The following is a description of a gene set: Human Gene Set: GOBP_NEGATIVE_REGULATION_OF_CELL_POPULATION_PROLIFERATION studied in species Homo sapiens Any process that stops, prevents or reduces the rate or extent of cell proliferation., and this is the list of marker genes: RC3H1, ABI1, P3H3, MIR200B, MAP2K1, PTPN1, PEX2, DNAJA3, MIR205, MIR15A, CNN1, GLMN, MIR26A1, WDR6, MIR1298, RNF139, MYOCD, SLIT3, MIR24-1, TP53, VTCN1, ACVR1C, MIR17HG, CCL3L3, PIM2, NUPR1 (NCBI Gene Id 26471, nuclear protein 1, transcriptional regulator), IFT52, SMAD6, CTLA4, LGALS9B, TNF, ZBTB7B (zinc finger and BTB domain containing 7B), JARID2, WNK2, MIR29C, PLPP1, PTPRU, PTGIR, HSPG2, MARCHF7, IL4I1, CERS2, BTG2, TESC, IGFBP7, TOB2, PPARD, NFIB, MYOD1, CD80, MED31, SFN, NF1 (neurofibromin 1), HMGA1, MIR4632, MIR221, EIF2AK2, CXCL8, MAGI2, DPT, IFNK, PLA2G5, FKTN, FGFRL1, WDR13, BCHE, NDRG4 (NCBI Gene Id 65009), CD300A, MIR495 (NCBI Gene Id 574453), STK4, NTRK1, CD33, TYROBP (transmembrane immune signaling adaptor TYROBP), MIR361, ECRG4 (NCBI Gene Id 84417), OVOL1, PHF14, MED25, IL12B, TMEM127, CCL8, ABCC8, TGIF1, ALDH1A2, MIR494, SULT2B1, AR, C1QL4, MIR20B, CER1, PTEN, CELF1, GATA3, NR2E3, PTPN2, CSK, ATP5F1A, APP, PAX6, VAX1, HGS, OVOL2, DLL1, PDCD10, TOB1, NDRG1 (NCBI Gene Id 7998), MIR22, KAT2B, MIR362, RBP4, SPARC, CLMN, KDM2B, WT1, PLAAT4, TAFA5, APLN, CHD5, MIR223, BTK, KLF9, ZBTB7C (NCBI Gene Id 649379), CLDN19, AXIN2 (NCBI Gene Id 8313), TENT5B, IL24, ATP8A2, PTPN14, RNF10, EMD, TMIGD3, SSTR4, P3H1, MIR181A2, AZGP1, SULF1, FZD5, ETS1, TREM2, ACKR3, MFN2, PKD2 (polycystin 2, transient receptor potential cation channel), SFRP5, SMARCA2, CGREF1, FLCN, SH2B3 (SH2B adaptor protein 3), IL12A, GABBR1, SYNJ2BP, HAVCR2, MN1, IFNLR1, MIR675, FABP7, GATA6, EAF2, SPEG, PHF7, ROBO1, ANG, MARVELD3, DRD2, UMOD, NMI, CSF1R, F2R (coagulation factor II thrombin receptor), RAPGEF2 (Rap guanine nucleotide exchange factor 2), GML (glycosylphosphatidylinositol anchored molecule like), BMP2, TNFRSF8, CSNK2B, HSPA1A, RNF41, MYC, NIBAN2, MIR133A1, ATG101, TNMD, TNFAIP3, ADAMTS1, MSX2, LGALS9, LILRB1, ZBTB17, TSG101, SLC16A2, MIR182, CCL23, NR2F2, IGFBP6, CDKN1A, CDKN2B, PAK1, MIR181C, FABP3, E2F1, SNAI2, IDO1, FLT1, MIR483, DELEC1, AGBL4, SSTR2, ZBTB49 (zinc finger and BTB domain containing 49), ADAMTS8, BRCA2, PAWR, FGFBP1, PTPRJ, MIR137, INTU, HRAS, DACH1, CTBP2, RBM38, PML, ETV3, IER3IP1, PRDX4, TMIGD1, RBM10, PHB2, GSDME, PDCD4, MIR199A1, IL20RB, OSM (NCBI Gene Id 5008), LAPTM5, DAB2, SOX11, ILK, FOXJ1, KLF13, NUP62, LYN, RARA, PTPN11, MIR204, FRZB, SLC6A4, BTN2A2, MYOG, LST1, IFT74, SH3BP4, MIR34A, PINX1, CRP, BCL6, ATG13, ADORA1, IAPP, ENG, TRIM24, HSF1, HNF4A, MIR16-1, GPC3, CYP27B1, DUX4, CDKN1B, GDF11 (NCBI Gene Id 10546), COL4A3, TGFB1I1, DAB2IP, WDR77, ATP5IF1, EEF1E1, PTPRK, MEN1 (menin 1), TNS2, PODN, BMP4, WNT11, CDKN2D, MIR320A, FXYD2, WNT10B, ACVRL1, MIR185, ATRAID, NUPR2, LILRB2, NPR1 (NCBI Gene Id 4881), FBXO2, MIR143, SMAD1, NCK2, IFNG, MIR329-1, MIR711, PLA2G2A, NGFR, CTCF, FABP6, ITCH, ULK1, PDX1, IFT80, MIR335, BAX, TINF2, HLA-DRB1, MTBP, FGF10, MSTN, ZBTB16, MIR34B, TSC1, TAF6, LILRB4, INPP5D, CD200, FEZF2, MIR2355, IFT57, ADGRG1, BMP7, TES (testin LIM domain protein), HPGDS (hematopoietic prostaglandin D synthase), IL2, RGS5, JAK2, VDR, GNRH1, IFNL1 (NCBI Gene Id 282618), H2AC8, CCN6 (cellular communication network factor 6), DLEC1, H2AC6, FOXP3, ATOH8, ERBB2, BAP1, TFAP2B, MIR92A1, SAV1, ING4, APOH, MIR486-1, FAP, SSTR3, PHB1, ADORA3, XCL1, KCNK2, MORC3, CNMD, TFDP1, CD86, FBLN1, ACE2, CCL2, NACC2, TNFRSF14, FGF2, KRT4, MED1, FOXO4, FBXW7, HLA-E, TMEM115, THAP12, KANK2, SRF, FGFR2, PTGES, MIR499A, RARRES1, AGTPBP1, ASPH, CDK10, MIR93, CLDN3, H2AC4, VSIG4, DHRS2, CDK6, S100A11, PARP10, NOG, KIFAP3, MIR140, SFRP2, LRRC32, PTPN6, BMPR1B, MIR503, A4GNT, LDOC1, GNA12, SMAD3, MIR20A, TRIM32, DLC1, CD109, SPIN4, MIR342, MIR1-1 (microRNA 1-1), RAP1GAP, SIX5, PKN1, CEACAM1, SCIN, STK3, SERPINE2, KMT2A, MTSS1, CBFA2T3, EFEMP2, PTHLH, DUSP10, P3H2, SMARCB1, HPN, INSM1, LIMS2, COL18A1, NF2, DSC1, INHBA, SLC4A2, MIR665, NUDT6, PLA2G2D, TP53INP1, LIF, BCL11B, RASSF5 (Ras association domain family member 5), MIR133B (microRNA 133b), TPM1, KLF4, MDM4, TSC22D1, PDPN, DDX20, TP73, DICER1, MNDA, MIR410, DLG3, SMAD4, SPINT2, MEF2C, CCN3, MIR9-1, DLG5, ARG2, TNFRSF9, MIR424 (NCBI Gene Id 494336), BECN1, IFT172, MIR34C (NCBI Gene Id 407042), GDF5, MIR152, MIR125B1, CDH5, CDKN2C, KRIT1, MIR497, PLA2G2F, E2F3, IGFBP3, LMNA, FTH1, SLURP1, GHRL, CDKN2A, DIS3L2, HRG, MAD1L1, KCTD11, SKI, ITGA1, TFAP4, APOD, MIR132, SPINT1, NKX2-8, ZNF503, SIRPG, BMPR2, COPS8 (COP9 signalosome subunit 8), GDF2, B4GALT1, PDCD1LG2, IL6, EIF2AK1, VGLL4 (NCBI Gene Id 9686), VASH1, PRNP, ENPP7, ARID2, KDF1, EPPK1, MIR195, TGFB2, ADORA2A, SPRY1, PBRM1, SCGB1A1, PRKAR1A, CEBPB, MIR125A, IL1B, NPM1, CTNNBIP1, RAF1, TP53I11, NME1, EPHB1, MIR492, ING5, CGRRF1, MMRN2, MIR15B, GPER1, CDC73, PMP22, STAT1, GPLD1, TSPAN32, MAGED1, LZTS2, WARS1, SRPX, HSPA1B, SFTPD, WWC2, PTH1R, ATM, SMAD7, CNOT7, SOD2, LTA, NOX4, LBX1, PTCH1, IGF1, MYO16, MIR10A, MIR29B1, ZEB1, NELL1 (neural EGFL like 1), B4GALT7, TNFRSF21, MIR30B, BTG1, TSC2, GAS8, FCGR2B, DHCR24, STRN, BMP5, FNIP1 (folliculin interacting protein 1), NKX3-1, CEND1, CTBP1, MSX1, SSTR5, RXFP2, IRF6, EREG (NCBI Gene Id 2069), FEZF1, ALOX5, PRKG1, GPNMB, TGFB3, GSTP1, SOX10, JUN, ATF5, DLL4 (NCBI Gene Id 54567), BAK1, RERG, PPARGC1A, MIR214, SF1, CEBPA (NCBI Gene Id 1050), MCC, CAV2, LGALS9C, TMEM131L, EFNB2, RBM5, TNFRSF13B, CDKN3, INPPL1, PTGDS, OGN, IL10, GTPBP4, VHL, MIR145, DNAJB2, TIAL1, SHOC2, TRIB1, MIR218-1 (microRNA 218-1), BTG3, GJB6, VSIR, MIR134, IFIT3, AQP11, PTN, PRKRA, IL33, TAX1BP3, CD37, PROX1, CYP1B1, MIR487B, WWC3, ARG1, IFI30, TGFB1, MIR126, MIR29A, ADRA1A, WWC1, IDH2, PRL, AKIRIN1, MIR23A, APOE, SFRP4, TGFBR3, GATA1, CDKN1C, SST (NCBI Gene Id 6750), NOTCH1, PPM1D, MIR892B, RB1, NOS3, IFI35, E2F7, MIR129-1, RB1CC1, MIR638 (microRNA 638), MIR98, TFAP2A, POU1F1, C18orf54, DDR1, RARG, SCRIB, INCA1, APPL2, STAT3, TBRG1, UTP20, SPRY2, NDFIP1 (NCBI Gene Id 80762), SMYD2, DLG1, ING1, OPRM1, ZNF268, MIR146A, CASK, SFRP1, SSTR1, PLXNB1, NEURL1, IRF1, TFF1, PHOX2B, CXCL1, ERBB4, PDE9A, RARB, HMOX1, NODAL, ST18, IL26, VSX2, SHH, SCG2, MIR222, GGNBP2, MIR449A, AIMP2 (NCBI Gene Id 7965), IFITM1, FUZ, NGF, IL1A, CD274, RUNX3, ENPP3, CASP3, SOX9, CDC6, TSPO, MIR149, BNIPL, AIF1 (NCBI Gene Id 9471), ADIPOQ, TPBG, WNT5A, MIR199B, ISL1, ZNF777, CLEC4G, CTNNA1, CR1, AIMP1, PLG, RIPOR2, ADGRB1, CACNB4, SERPINF1, SIRT2, PTK2B, MIR873, PDS5B, MIR30C2, TWSG1, KLF10, AVPR2, BTG4 (BTG anti-proliferation factor 4), WNT9A, MIR138-1, MAPK11, PTGDR2, CHERP, MIR378A, GAL, RGCC, SIRT6, PPARG, AMBRA1, TBX5, NPPC, FERMT1, CDH13, THBS1, ITGB1BP1, PPP2R5C (NCBI Gene Id 63377), GLI3, CXCR3, NHERF1, NR2E1, TGFBR1, GATA2, MIR21, IHH, TMEM196, RBPJ, CAV1, DUSP1, IL2RA, RBBP4, CRTAM, FBXO4, IGFBP5, SDC4, RPS6KA2, PTPRM, SKAP2, BTLA, ALOX15B, TENM1, PELI1, MIR30E, ASCL2, STK11, ADARB1, MIR339, CD9, MINAR1, PER2, BCL2, HLA-G, MIR193A, KLF11, NLRC3, APC, NDRG2, B2M, MIR96, SPN, TBX3, DDAH1 (NCBI Gene Id 23576), CIB1, GREM1, RIPPLY3, CBLB, CTNNB1, HES1 (hes family bHLH transcription factor 1)